The following is a description of a gene set: studied in species Homo sapiens Human Gene Set: GOMF_NEUROPILIN_BINDING Binding to a member of the neuropilin family., and this is the list of marker genes: SEMA3E, SEMA4A, SEMA3F, SEMA4F, VEGFA, SEMA4G, ABL1, SEMA7A, SEMA4D, SEMA3C, TAOK2, SEMA4B, SEMA3A, SEMA3B, SEMA3G, SEMA3D, SEMA4C, PXN